Given this list of marker genes Suv39h1, Mettl18, Eif2a, Rrp7a, Ddx54, Fdxacb1, Rpl26, Rbm10, Cul4b, Rpp25, Greb1l, Utp4, Sde2, Xrcc5, Nop10, Mrm1, Mterf3, Cdkn2a, Imp3, Ngrn, Zfp593, Utp14a, Abcf1, Utp23 (UTP23 small subunit processome component), Rcl1, Gtf2h5, Nom1, Wdr18, Pes1, Nop9, LTO1, Utp6, Tsr2, Drosha, 1700009N14Rik, Airim, Nop16, Pop5, Rps14, Pdcd11, Gar1, Heatr3, Nop56, Exosc7, Rpusd1, Surf6, Ddx17, Ltv1, Ddx49, Rps19, Rps27rt, Dis3, Rsl24d1, Bms1, Ddx56, Eif1ax, Nol6, Lsg1, Rrn3, Rps28, Nat10, Zfp622, Bysl, Wdr43, Rps27a, Esf1, Utp3, Pih1d2, Ybey, Nsun4, Dcaf13, Tbl3, Rpl7a, Naf1, Pak1ip1, Mrps7, Urb1, Nol9, Utp11, Frg1, Xpo1, Tma16, D1Pas1, Ebna1bp2, Prkdc, Rps27, Dicer1, Afg2b, Ipo9, Glul, Imp4, Rps19bp1, Rps13, Rpusd4, Tfb2m, Nop58, Rps24, Nol7, Ddx51, Wdr55, Rpl7, Dhx30, Rps12, Mtrex, Fbl, Ddx3x, Nob1, Rpf1, Ddx28, Nle1, Mterf4, Dnttip2, Riox2, Nol8 (NCBI Gene Id 70930), 2810004N23Rik, Afg2a, Zfp658, Pa2g4, Efl1, Ran, Tent4b, C1qbp, Rrp1b, Pwp2, Noc2l, Rpl38, Sart1, Ddx18, Rpp38, Snu13, Nup88, Ngdn, Pelp1, Rpl11, Exosc9, Wdr74, Emg1, Rasl2-9, Rps3a1, Ak6, Fcf1, Exosc2, Utp14b, Usp16, Chd7, Rps15, Eif1a, Gtpbp4, Rbfa, Mdn1, Kat2b, Mettl5, Riok1, Dhx37, Usp36, Rps5, Sdad1, Rexo5, Rps8, Ddx47, Bud23, Ipo4, Rps6-ps4, Mcat, Isg20l2, Rpl5, Trmt2b, Malsu1, Tfb1m, Pin4, Nmd3, Mettl16, Pwp1, Las1l, Tsr1, Exosc10, Nsun3 (NOL1/NOP2/Sun domain family member 3), Rplp0, Sbds, Noc4l, Rpl27, Rps23 (ribosomal protein S23), Nvl, Rbis, Riox1, Lyar, Rrp1, Exosc8, Mettl17, Gtpbp10, Znhit6, Rps16, Urb2, Rpsa, Dimt1, Rps6, Rnasel, Ddx31, Nol10 (nucleolar protein 10), Wdr75, mt-Rnr2, Exosc5, Tsc1, Noa1, Fau, Mpv17l, Riok3, Mpv17l2, Rbm34, Utp15, Mrto4, Ppan, Eif5, Rexo1, Rps4x, Mrm2, Npm3, Nol11, Rrp9, Srfbp1, Wdr36, Dkc1, Bop1, Rpp40, Nhp2, Nip7, Fbll1, Nsa2, Rpl24, Mettl15, Riok2, Cinp, Mrm3, Myg1, Rps11, Rps21, Nsun5, Pten, Pop7, Dhx29, Gnl3l, Krr1, Tsr3, Pop4, Mrpl10, Aatf, Rpf2, Grwd1, Gtf3a, Sirt7, Ddx10, Mak16, Ddx27, Rrp15, Utp18, Rps9, Exosc3, C1d, Nudt16, Zfp735, Isg20, Rcc1l, Rpusd2 (RNA pseudouridylate synthase domain containing 2), Wdr3, Rpl35a, Rexo4, Rps27l, Mrps2, Rps7, Ddx21, Exosc6, Ythdf2, Ftsj3, mt-Rnr1, Utp20, Exosc4, Rps25, Fastkd2, Nop2, Rps15a (ribosomal protein S15A), Pih1d1, Mybbp1a, Mphosph6, Wdr46, Ncl, Rrs1, Npm1, Nop14, Cul4a, Zfp616, Eif6, Zcchc4, Pno1, Wbp11, Abt1, Mphosph10, Rps17, Rpl35, Znhit3, Utp25, Kri1, Eri1, Heatr1 (HEAT repeat containing 1), Lsm6, Exosc1, Ercc2, Rpl14, Eif4a3 (NCBI Gene Id 76481), Nop53, Rpl10l (ribosomal protein L10-like), Ddx52, Eral1, Rpp30, Rpl7l1, Trmt112, Rrp8, Brix1, Rrp36, Slx9, Eif5b, Wdr12, Gnl2, here is a description of the gene set: A cellular process that results in the biosynthesis of constituent macromolecules, assembly, and arrangement of constituent parts of ribosome subunits; includes transport to the sites of protein synthesis. Mouse Gene Set: GOBP_RIBOSOME_BIOGENESIS studied in species Mus musculus